The following is a description of a gene set: Mouse Gene Set: GOBP_PHOTOTRANSDUCTION_VISIBLE_LIGHT species: Mus musculus The sequence of reactions within a cell required to convert absorbed photons from visible light into a molecular signal. A visible light stimulus is electromagnetic radiation that can be perceived visually by an organism; for organisms lacking a visual system, this can be defined as light with a wavelength within the range 380 to 780 nm., and this is the list of marker genes: Ttr, Rho, Pde6c, Rbp4, Pcp2, Gnb1, Gnat3, Pnpla2 (patatin-like phospholipase domain containing 2), Aipl1, Gnat1, Grk1